Given this list of marker genes Wfs1, Akap11, Nfat5, Inpp5k, Aqp2, Has2, Mllt6, Aqp4, Adcy6, Aqp1, Aqp6, Sctr, Umod, Atp6v1b1, Ctns, Aqp7, Aqp3, Akr1b1, Hyal2, here is a description of the gene set: Renal process involved in the maintenance of an internal steady state of water in the body. Mouse Gene Set: GOBP_RENAL_WATER_HOMEOSTASIS species: Mus musculus